Given this list of marker genes SYNJ1, PEX5, SLC2A1, MAST3, CNTNAP2, CACNA1A, PCDH19, DEPDC5, VAMP2, here is a description of the gene set: Convulsive status epilepticus Human Gene Set: HP_CONVULSIVE_STATUS_EPILEPTICUS studied in species Homo sapiens A type of status epilepticus characterized by a prolonged bilateral tonic-clonic seizure, or repeated bilateral tonic-clonic seizures without recovery between.